Given this list of marker genes Uvrag, Lmtk2, Bves, Rep15, Laptm5, Smurf1, Abca2, Nsf, Cdk5, Eps15, Grin2a, Psen2, Capn1, Plekha3, Scrib, Plekhj1, Git1, Znrf3, Snx25, Rab11b, Tgfb1, Pex5, Apoe, Ctsd, Pex1, Snx16, Mtmr2, Inpp5f, Pik3r4, Als2, Nedd4, Tbc1d16, Vamp3, Becn1, Rnf43, Pheta1, Dab2, Gria1, Ldlr, Ece1, Lgmn, Pex10, Kif16b, Pcsk9, Chmp5, Dtx3l, Psen1, Pex12, Ache, Sorl1 (NCBI Gene Id 72910), Ptpn2, Ptpn1, Agtr1a, Mylip, Optn, Nedd4l, Nsg1 (NCBI Gene Id 18196), Sh3glb1, Hamp, Caml, Gria2, Becn2, Arfgef2, Anxa2, Furin, Ehd3, Itch, Gprasp1, Trat1, Ramp3, Pex6, Pex2 (peroxisomal biogenesis factor 2), Ap1ar, Snca, Usp9x, Pheta2, Mvb12a, Lamtor1, Rab29, Hamp2, Fut8, Ide, Gria3, Arap1, here is a description of the gene set: studied in species Mus musculus Mouse Gene Set: GOBP_RECEPTOR_METABOLIC_PROCESS The chemical reactions and pathways involving a receptor molecule, a macromolecule that undergoes combination with a hormone, neurotransmitter, drug or intracellular messenger to initiate a change in cell function.